The following is a description of a gene set: studied in species Homo sapiens Human Gene Set: GOMF_SULFOTRANSFERASE_ACTIVITY Catalysis of the transfer of a sulfate group from 3'-phosphoadenosine 5'-phosphosulfate to the hydroxyl group of an acceptor, producing the sulfated derivative and 3'-phosphoadenosine 5'-phosphate., and this is the list of marker genes: HS3ST4, CHST14, SULT2A1, SULT1A1, HS3ST1, HS2ST1, CHST13, GAL3ST3, SULT1B1, NDST4, UST, HS3ST3A1, HS3ST3B1, SULT1C3, SULT1C2 (sulfotransferase family 1C member 2), NDST3, HS6ST1, CHST2, CHST3, GAL3ST2, GAL3ST4, HS3ST6, CHST10, GAL3ST1, CHST1, TPST1, CHST12, CHST8, CHST7, WSCD2, WSCD1 (WSC domain containing 1), SULT2B1, HS6ST3, HS6ST2, CHST5, HS3ST5 (NCBI Gene Id 222537), CHST4, CHST6, CHST11, DSEL, SULT6B1, HS3ST2, NDST2 (N-deacetylase and N-sulfotransferase 2), CHST15, SULT1E1, SULT1C4, SULT1A4, SULT4A1, SULT1A3, SULT1A2, TPST2, NDST1, CHST9